Given this list of marker genes UGP2, RGS3, GNPDA2 (NCBI Gene Id 132789), PEAK1, SOCS6, C19orf12, DUSP10, HAND2, CBLN4, PRKAR2B, RBM27, ITPRID2, SERTAD3, LIMCH1, ZNF521, SLC9A1, LATS2, REST, HIVEP1, ZFHX4, TOB2, EDEM1, GID4, DSC2, BSN, GNAQ, SOX4, MAP1B, EPG5, PAX9, MTF1, MEF2D, SLC7A11, MFHAS1, APBB2, ACOX1, OSBPL5, KLF2, MAPK8, GTF2A1, TBL1XR1, TENT4A, RSBN1, PGBD2, SNX13, TMEM255A, BCL2L11, KLHL14, TAFA1, CCDC186, ZNF721, PCGF3, UCHL5, FNBP4, EDEM3, RAB3C, C21orf91, DNAAF9, HERPUD2, PKDCC (NCBI Gene Id 91461), SLC24A3, HIPK1, SLC10A7, GOLGA7, ZFAND1, AIDA, MPP1, RPS6KA4, MFF, NUFIP2, RAD21, PLEKHA1, MAP2K4, MAP3K20, MYCBP2, DUSP5, RANBP9, MCL1, MIER1, SLC25A16, ARMC1, FHIP1B, ASPN, UBE2W, ITGA6, ESRP1 (epithelial splicing regulatory protein 1), PPCS, SGPP1, COG3, ALKAL2, MYO1B, FBN1, ZC2HC1A, COX20, WASL, MAN2A1, MARCHF6, MMP10, LONRF3, ACTC1 (actin alpha cardiac muscle 1), ADAMTSL3, ADRB1, TULP4, PIK3R3, SLC25A36, SNN, SNAP91, RORA, ADAMTSL1 (ADAMTS like 1), FBXW7, DPP10, NCAPH2, ZFC3H1, CLDN11 (claudin 11), IBTK, SLC17A6, SLC32A1, AGO3, BTG2, ITGA8, FHL2, MOAP1, SCN8A, REXO1, EOMES, CNIH1, MORC3, CDK16, NSMF, ST6GAL2, MMD, ANKRD28, NFYB, SNAPC1, KLHDC10, BLTP1, CPEB4, HYCC2, USP36, TCF21, RNF44, MYO5A, DMXL1, SLC12A5, ZNF385D, C8orf44-SGK3, MAGEC2, INSIG1, FOXN2, LMBR1L, CACNA1I, LRCH1, GRHL1, RBPMS2, RIMS2, PHTF2, NCKAP5, SLX4, USP45, SLC4A8 (solute carrier family 4 member 8), CADM2, GLYR1, YIPF4, RNF141, NPNT, COL19A1, CUX1, TMEM267, TBC1D8, GRAMD2B, ANP32E, SGK3, KLHL29 (kelch like family member 29), ARHGEF17, FAM135A, GFPT2, MTMR9, G3BP2, TPPP, KMT5B, DDX3Y, NF2, MIA3, PDZD2, ZNF595, DAAM1, MSR1, DENND4B, PPP1R12C, NKX2-3, DNAJB9, TWF1, RPL15, EFR3A, CPEB2, PCYT1B, CNEP1R1, SLC38A2, BCAT2, CCNC, GPR137C, JOSD1, FHIP2A, IQGAP2, BCL11A, C6orf62, ANKRD44, GATA2, STYX, PLEKHB2, PTPRD, PITPNA, NPC1, ERGIC2, DENND1B, NSF, PDE10A, ATP6V1B2, PLEKHG3, RHPN2, TRIO, TBC1D12, PNISR, OTUD3, ATXN1, MARCHF4, RNF4, ADCY3 (NCBI Gene Id 9608), CPNE8, AFF3, FXR1, TEF, BMPR2, NSMAF (neutral sphingomyelinase activation associated factor), MBOAT2, FMN2, EPC2, PHLPP2, CDCA7L, KBTBD8, ITGAV, PTPRO, ITPR1, HIPK3, ATRX, GOLGA1, CPEB3, PSMD14, TOB1, CSMD3, SLC39A8, PITPNM2, PTEN, ELOA, ZNF24, PIAS4, SOSTDC1, GLRA1, SYN2, ZEB2, TPCN1, ANKIB1, SCUBE3, CELF2, NEFM, C5orf24, FAM24A, PRRC2B, GPR158, UBASH3B, PAX3, MINAR1, ZDHHC5, CXCL5, KLHL15, ADGRF2P, LRRC1, C11orf24, ADAM10, ARF1, ATXN3, UBXN4 (NCBI Gene Id 23190), FZD10, RIC1, PTPRK, CIC, PAPSS2 (3'-phosphoadenosine 5'-phosphosulfate synthase 2), DUS2, PCDH11X, FCHO2 (FCH and mu domain containing endocytic adaptor 2), MACIR, NEFL, FNIP1, NEFH, GATA6, GOLGA4, SSBP2, SLC25A32, PALLD, PDZD8, SEMA3A, SPRYD4, SLC9A7, FKBP1A, CTTNBP2, SETD5, DNAJB12, PER2, MYH9, PIK3CB, TACC2, USP28, SH3D19, NOX4, ELOVL4, KAT2B, SYNJ1, RNF180, RFX1, CASD1, UBE2Z, IDH1, CD69, ARID1B, IL36B, SPTBN4, B3GALT2, CCNJL, GPC6, HNF1B, PTAR1, TMEM229A, RAB8B, SESN3, GPR180, SELENOT, PIKFYVE, DYRK2, ROBO2, TECPR2, ZNF827, TTC9, TMF1, VPS4B, LIN54, ZFYVE21, KLF8, FNIP2, BAZ2B, TAGAP, CLCN5, KLF4, SH3PXD2A, SOX11, PCDH11Y, TEAD1, COL27A1, CD2AP, CBFA2T3, HS3ST5, LYST, HCN2, ARHGAP24, OTUD4, ABHD13, NKX2-4, DDX3X, PTGER4, PPP1R12A, RAB14, CDKL5, RAB23, ADAM19, SRPRA, ELK4, P3H3, DCAF6, RGL1, AADACL3, PAXBP1, TGIF1, MAST4, BAHCC1, TET2, FAM20C, ARRDC3, ANO8, LUZP1, PLXDC2, MED19, BCL11B, PCDH7, GOLGA3, TRIM36, EVI5, CALN1, JMY, RBM47, ITGA5, PCMTD1, SCAF11, PTPRJ, COL1A2, NR4A3, XPNPEP3, WWP2, CHCHD10 (NCBI Gene Id 400916), APPL1, XYLT2, GIT2, ZNF287, ARRDC4, FRY, DOCK9, PCOLCE2, TEX2, ATG14, BSDC1, LHFPL2, RNF38, STRN3, GLCE, TNPO1, RGS17, PPP1R37, here is a description of the gene set: Genes predicted to be targets of miRBase v22 microRNA hsa-miR-363-3p in miRDB v6.0 with MirTarget v4 prediction scores > 80 (high confidence targets). from publication Chen Y, Wang X (PMID 31504780) species: Homo sapiens Human Gene Set: MIR363_3P